Given this list of marker genes LGALS3, TNFRSF1B, DTYMK, RUNX1, CDA, TRBC2, MYBL2, CD2, TRAC, ITGB2, BCL2A1, TCF7, FCGR3B, CD6, FOLR1, CXCR1, LCK, TMSB15A, CD3E, CSF1R, here is a description of the gene set: Human T cell leukemias can arise from oncogenes activated by specific chromosomal translocations involving the T cell receptor genes. Here we show that five different T cell oncogenes (HOX11, TAL1, LYL1, LMO1, and LMO2) are often aberrantly expressed in the absence of chromosomal abnormalities. Using oligonucleotide microarrays, we identified several gene expression signatures that were indicative of leukemic arrest at specific stages of normal thymocyte development: LYL1+ signature (pro-T), HOX11+ (early cortical thymocyte), and TAL1+ (late cortical thymocyte). Hierarchical clustering analysis of gene expression signatures grouped samples according to their shared oncogenic pathways and identified HOX11L2 activation as a novel event in T cell leukemogenesis. These findings have clinical importance, since HOX11 activation is significantly associated with a favorable prognosis, while expression of TAL1, LYL1, or, surprisingly, HOX11L2 confers a much worse response to treatment. Our results illustrate the power of gene expression profiles to elucidate transformation pathways relevant to human leukemia. from publication Ferrando AA, Neuberg DS, Staunton J, Loh ML, Huard C, Raimondi SC, Behm FG, Pui CH, Downing JR, Gilliland DG, Lander ES, Golub TR, Look AT (PMID 12086890) studied in species Homo sapiens Human Gene Set: FERRANDO_TAL1_NEIGHBORS Nearest neighbors of TAL1, based on the close agreement of their expression profiles with that of TAL1 in pediatric T cell acute lymphoblastic leukemia (T-ALL)